Given this list of marker genes LMNA, NECTIN4, CDH3, DSG4, ST14, TP63, PEX6, BCS1L, ASL, WRN, NECTIN1, HEPHL1, ERCC2, KRT85, PEX1, ATP7A, here is a description of the gene set: Pili torti species: Homo sapiens Pili (from Latin pilus, hair) torti (from Latin tortus, twisted) refers to short and brittle hairs that appear flattened and twisted when viewed through a microscope. Human Gene Set: HP_PILI_TORTI